The following is a description of a gene set: Cluster 1 of genes distinguishing among different B lymphocyte neoplasms. from publication Shin DM, Shaffer DJ, Wang H, Roopenian DC, Morse HC 3rd (PMID 19010892) studied in species Mus musculus Human Gene Set: SHIN_B_CELL_LYMPHOMA_CLUSTER_1 Aside from Myc-activating translocations characteristic of plasmacytomas (PCT), little is known about genetic factors and signaling pathways responsible for the development of spontaneous B-cell lineage lymphomas of mice. Here, we characterized the transcriptional profiles of PCT, centroblastic diffuse large B-cell lymphomas (CBL), and high-grade splenic marginal zone B-cell lymphoma (MZL++) using high-throughput quantitative reverse transcription-PCR. Expression profiles of CBL and MZL++ were strikingly similar and quite unlike that of PCT. Among the genes expressed at significantly higher levels by PCT were a number involved in NOTCH signaling, a finding supported by gene set enrichment analyses of microarray data. To investigate the importance of this pathway, NOTCH signaling was blocked in PCT cell lines by treatment with a gamma-secretase inhibitor (GSI) or transduction of a dominant-negative mutant of MAML1. These treatments resulted in reduced expression of NOTCH transcriptional targets in association with impaired proliferation and increased apoptosis. GSI treatment of transformed plasma cells in a primary PCT also induced apoptosis. These results integrate NOTCH activation with oncogenic signaling pathways downstream of translocated Myc in the pathogenesis of mouse PCT, two signaling pathways also implicated in development of human multiple myeloma and T-cell lymphoblastic lymphoma., and this is the list of marker genes: MNX1, DVL2, HELLS, NOS2, HOXD11, TCL1A, IRF1, RAD52, IL10, IFNG, PTCH2, CXCL9, CCL3